The following is a description of a gene set: part of: Signaling by FGFR1 Reactome Pathway: Downstream signaling of activated FGFR1 species: Homo sapiens Signaling via FGFRs is mediated via direct recruitment of signaling proteins that bind to tyrosine auto-phosphorylation sites on the activated receptor and via closely linked docking proteins that become tyrosine phosphorylated in response to FGF-stimulation and form a complex with additional complement of signaling proteins. <br><br>The activation loop in the catalytic domain of FGFR maintains the PTK domain in an inactive or low activity state. The activation-loop of FGFR1, for instance, contains two tyrosine residues that must be autophosphorylated for maintaining the catalytic domain in an active state. In the autoinhibited configuration, a kinase invariant proline residue at the C-terminal end of the activation loop interferes with substrate binding while allowing access to ATP in the nucleotide binding site.<br>In addition to the catalytic PTK core, the cytoplasmic domain of FGFR contains several regulatory sequences. The juxtamembrane domain of FGFRs is considerably longer than that of other receptor tyrosine kinases. This region contains a highly conserved sequence that serves as a binding site for the phosphotyrosine binding (PTB) domain of FRS2. A variety of signaling proteins are phosphorylated in response to FGF stimulation, including Shc, phospholipase-C gamma and FRS2 leading to stimulation of intracellular signaling pathways that control cell proliferation, cell differentiation, cell migration, cell survival and cell shape., and this is the list of marker genes: GAB1, FLRT2, FGF22, KL, SOS1 (SOS Ras/Rac guanine nucleotide exchange factor 1), FGF23, FRS2, FGF20, FRS3, FLRT3, PIK3CA, FGF5, FGF6, SHC1, FGF3, KRAS, HRAS, FGF9, FLRT1, FGFR1, FGF10, PLCG1, FGF2, PTPN11, FGF4, FGF17, GRB2, FGF1, FGF8, NRAS, PIK3R1